The following is a description of a gene set: Human Gene Set: GSE3039_CD4_TCELL_VS_ALPHABETA_CD8_TCELL_UP species: Homo sapiens Three innate (B1-B, NKT, CD8aaT cells) and adaptive (B2-B, CD4T, CD8abT cells) cell-types were sorted by FACS. Three biological replicates for NKT, CD4T, CD8aaT, CD8abT cells and two biological replicates for B1 and B2 cells were generated and the expression profiles were determined using Affymetrix Mu74Av2 chip. Comparisons between the sample groups allow the identification of genes differentially expressed between the innate and adaptive cell-types. from publication Yamagata T, Benoist C, Mathis D (PMID 16623764) Genes up-regulated in T cells: CD4 versus CD8A CD8B., and this is the list of marker genes: MARVELD1, ADPGK, MEFV, FOSB, PYGL, ABCC5, TRPM2, SLC4A1, SCRG1, PHLDB2, HEMGN, DUSP1, NCF4, SFI1, PITPNC1, KIAA0586, PCNX1, CYBB, ANKRD13D, APOE, IRF1, S1PR4, UBA7, PLAGL1, GAS6 (NCBI Gene Id 2621), MXD1, UBE2L6, TEX15, NCF1 (NCBI Gene Id 653844), OLFM4, ABI3BP, MS4A6A, NCAM1, ADTRP, HP, CDK5R1, HCST, LPCAT1, HAS2, LATS2, ABCC9, ADAM19, H3C14, HLA-C, VSIG10, MYL12B, S100B, MOGAT2, MPZL1, TFEB, H1-2, SERTAD3, ATP2A3, COX6B2, OTUD7B, SLC6A7, FAR2, HEPH, KDM6B, TTC21A, TMCC2, MAP3K5, BGN, CTSG (cathepsin G), S1PR5, MATCAP2, PHF20L1, LYVE1, ARHGAP9, DAPL1, C1QTNF12, MCU, PTGS2, C1QB, TRIB1, NFYB, SMAD3, CYP27A1, PRKCI, CNMD, CDK2, FER, BACE1, CD300C, RAD52, FABP4, PIAS3, TRIB2, TNFSF13B, SP110, PTPRC, FAP, CD5L, DGKH, PPP1R35, GRINA, LHFPL6, ZBTB26, PDE4D, PURG, BTNL9, PRG2, OVGP1, DUSP2, MMP8, PLTP, LTA4H, SLC2A3, PGLYRP1, MBD6, EPM2AIP1, HSPA1A, CYFIP2, PCP4, TBC1D25, SH3BP5L, TIAM2, CHST13 (carbohydrate sulfotransferase 13), IGLC7, THBD, PAXX, SIGLEC10, CALHM6, SSH2, SUN2, TNC, LMNB1, APOBEC1, GLCCI1, OLFML3, IFIT1, ASB7, FAM221A, B2M, FCN1, HOXB4 (NCBI Gene Id 3214), JCHAIN, CTSE, GALNS, PRDX5, MCTP1, ANXA1, GOLM2, WDTC1, SLPI, DSTN, CNN3, IFNLR1, TMEM38B, ANKRD12, FCMR, ING1, NRM (nurim), FBXO10, SEC22C, FAM221B, CCR3, LCT, GARIN3, FSTL1, PROK2, KHK, NR4A1, UBE2H, SYNE1, ADIPOQ, VCL, SEMA4F, TINAGL1, OAZ1, PDGFC, SEPTIN1, TIMM17B, MAPK4, MTMR3, DACH1, FCRL1, SERPINB1, CFH, ELANE, R3HDM4, OSM, PLPP3, SORD, PDE2A, SERPING1, ZNF212, HK3, MCTP2, TNKS1BP1, EPAS1, ARHGEF37, MMP9, USP53, ALOX15, CSF3R, MSANTD3, TMOD4, ARMC8, LBR